Given this list of marker genes ATP6V1E2, ATP6V1F, RNASEK, ATP6V0A2, ATP5MK, SPAAR (NCBI Gene Id 158376), ATP6V1E1, ATP6V1C1, ATP6V1G2, ATP5MC2, DMAC2L, ATP5MG, ATP6V1C2, ATP6V1A, ATP6V0D1 (ATPase H+ transporting V0 subunit d1), ATP5PF, ATP6V1B1, CCDC115, ATP6V1G3, ATP6V1B2, ATP5F1B, ATP6AP1, ATP6V1H, ATP6V0C, ATP6V1G1, ATP6V0E2, ATP5MC3, ATP5F1EP2, MT-ATP8, ATP6V0A1, ATP6V0D2, ATP5ME, TMEM199, ATP6V0A4, ATP5PB, ATP5PO, ATP5MF, ATP5MGL, ATP5F1C, ATP6V0E1, ATP6V0B, ATP5F1E, ATP6AP2, ATP6V1D, TCIRG1, ATP5F1D, MT-ATP6, ATP5F1A, ATP5MC1, ATP5MJ, ATP5PD, here is a description of the gene set: Human Gene Set: GOCC_PROTON_TRANSPORTING_TWO_SECTOR_ATPASE_COMPLEX species: Homo sapiens A large protein complex that catalyzes the synthesis or hydrolysis of ATP by a rotational mechanism, coupled to the transport of protons across a membrane. The complex comprises a membrane sector (F0, V0, or A0) that carries out proton transport and a cytoplasmic compartment sector (F1, V1, or A1) that catalyzes ATP synthesis or hydrolysis. Two major types have been characterized: V-type ATPases couple ATP hydrolysis to the transport of protons across a concentration gradient, whereas F-type ATPases, also known as ATP synthases, normally run in the reverse direction to utilize energy from a proton concentration or electrochemical gradient to synthesize ATP. A third type, A-type ATPases have been found in archaea, and are closely related to eukaryotic V-type ATPases but are reversible.